The following is a description of a gene set: Human Gene Set: HP_PITUITARY_GROWTH_HORMONE_CELL_ADENOMA species: Homo sapiens A type of pituitary adenoma that produces growth hormone. Pituitary growth hormone cell adenoma, and this is the list of marker genes: GNAS (GNAS complex locus, NCBI Gene Id 82944), GPR101, CDKN1A, GANAB, ALG9, AIP, PDE11A, PKD2, IFT140, PRKAR1A, BICC1, CDKN1B, DNAJB11, ALG5, CDKN2B, MEN1, PKD1, CDKN2C